The following is a description of a gene set: studied in species Homo sapiens Human Gene Set: GOBP_POSITIVE_REGULATION_OF_CARBOHYDRATE_METABOLIC_PROCESS Any process that activates or increases the frequency, rate or extent of the chemical reactions and pathways involving carbohydrate., and this is the list of marker genes: PRKAG1, ADCYAP1R1, ARPP19, INSR, GPLD1, KAT2A, KAT2B, PRKAG2, CD244, PMAIP1, NFKB1, PPP1CA, SLC4A4, NNMT, SNCA, AKT2, EGF, EPM2AIP1, CRY1, PTH, MTOR, HTR2A, ZBTB20, PPP1R3E, MLXIPL, DDB1, WDR5, MLST8, PSEN1, PRKACA, UCHL1, IFNG, SRC, ACTN3, AKT1, MIR210, PPP4R3A, PDGFB, GCK, PPP1R3B, PPP1R3G, IRS2, IRS1, GAPDHS (glyceraldehyde-3-phosphate dehydrogenase, spermatogenic), SORBS1, IGF2, HAS2, MIR107, PTPN2, PHKA1, PHKG2, SIRT7, PPP4R3B, PRKAA2, GPD1, PTH1R, HIF1A, P2RY6, SIRT1, FOXO1, GPER1, HMGB1, ARNT, IGF1, DGAT2, NTSR1, P2RY1, PRKAA1, LHCGR, ADCY10, MIR103A1, PPARA, INS, P2RX7, PRKAG3 (NCBI Gene Id 53632), PPARGC1A, DYRK2, RPTOR, GCG, APP, PRXL2C, SLC45A3, AVPR1B